Given this list of marker genes C1QL1, ADGRB3, KCNK13, TREM2 (NCBI Gene Id 54209), ITGB1 (NCBI Gene Id 3688), VANGL2, PLXNC1, NGEF, SARM1, EPHA4, here is a description of the gene set: studied in species Homo sapiens Human Gene Set: GOBP_REGULATION_OF_SYNAPSE_PRUNING Any process that modulates the frequency, rate or extent of synapse pruning.